The following is a description of a gene set: species: Homo sapiens The expansion, trafficking and functional effectiveness of adoptively transferred CD8+ T-cells play a critical role in mediating effective anti-tumor immunity. However, the mechanisms which program the highly proliferative and functional state of CD8+ T-cells are not completely understood. We hypothesized that IL-12, a cytokine commonly induced by TLR activation, could enhance T-cell priming by altering responsiveness to antigen and cytokines. Priming of tumor specific CD8+ T-cells in the presence of IL-12 induced the acquisition of a 'polyfunctional' effector response and increased the generation of memory cells. Moreover, IL-12 priming also promoted high levels of the IL-2 receptor alpha-chain (CD25) and robust IL-2 mediated activation of STAT5. This sensitivity to IL-2 translated into enhanced in vivo proliferation of adoptively transferred CD8+ T-cells. Furthermore, real-time, in vivo imaging of T-cell trafficking confirmed the ability of IL-12 priming to drive in vivo proliferation. IL-12 priming enhanced the anti-tumor function of adoptively transferred cells by reducing established subcutaneous tumor burden, and significantly increasing survival in an established intracranial tumor model. Finally, IL-12 priming of human PBMCs generates tumor specific T-cells phenotypically and functionally similar to IL-12 primed Pmel-1 T-cells. These results highlight IL-12 as an important mediator of CD8+ T-cell effector function and anti-tumor immunity. Human Gene Set: GSE22443_IL2_VS_IL12_TREATED_ACT_CD8_TCELL_UP Genes up-regulated in Pmel-1 CD8 T cells primed with cognate antigen: IL2 versus IL-12. from publication Lisiero DN, Soto H, Liau LM, Prins RM (PMID 21430221), and this is the list of marker genes: KRTAP4-3, RGL1, ACY3, GALNT10, PEX5, IFNB1, BBS7, TMEM52, CYP11B2, DMAC2, USP9Y, NUP188, SKA1, ABHD16A, NR2E3, LRRN3, VPS8, PTPN5, CLCNKB, MTMR2, RHOBTB3, PMP2, TEX261, PIGP, CAPN3, NRGN, TMEM91, KIF6, EFNA4, TMEM252, LIFR, DAB1, EGFR, CHRDL2, SSBP4, DMC1, NFKBIL1, RNF208, AKAP5, PIP5KL1, HRG (NCBI Gene Id 3273), SFRP4, CFAP36, TMEM102, MFN2, TMEM44, HOOK2, FAM83F, MATN3 (matrilin 3), FSTL5, VAMP1, RAB11FIP3 (NCBI Gene Id 9727), RAG2, LYZL4, NETO1, SMAD9, KHDC3L, ADGRF5, AIFM3, SLC38A7, ASCL2 (NCBI Gene Id 430), LOXL1, LIAT1, AUTS2, TBX5, ZNF565, CXCL13 (C-X-C motif chemokine ligand 13), CHGB, SLFN13, DNAAF4, FUT1, NOL3, STRBP, HPDL, FOXJ1, RNASEH2C, ALDH7A1, RNF126, RFC1, FOXD2 (forkhead box D2), TRIM71, GCM1, OTUD7A, MTNAP1, SLC4A11, NTRK1, PIGR, LAMA1, FOLR1, PTGES2, WFDC5, KERA, BNIP5, GJB5, REXO4, TRMT1, B3GALT1, TMEM131L, C14orf28, SLC26A5, TEX101, CASR, ENSG00000286190, LAP3, PSMF1, XRCC5, GSTZ1, CRYGS, FHIP1A, PAQR6, SEPHS1, HCFC2, PRTN3, TCEA2, PPP4R4, CAPN11, MRPL46, KRT27, TCL1A, MAP2, SLC7A14, STAC, PRELP, DYRK3, TRH, NKD1, TRIM42, PI4KB, NKPD1, DBNDD2, CBX6, TNFAIP8L1, SDCCAG8, RRP12, LIPF, HSF2BP, BCL2L14, RWDD2A, TAF3, FAM234B, CLDN16, TTI2, UPB1, NCAPH2, PIGK, CCR4, CALY, DCLRE1A, ZP1, HOXD11, TACR1, HACL1, MND1, SUDS3, C1orf54, AATK, P2RX3 (purinergic receptor P2X 3), TNNI3K (NCBI Gene Id 51086), MPV17L2, ST6GALNAC6, MRPS22, TRMT9B, NR1H3, CLDN14, CENPB, ATCAY, FKBP6, TMEM130, SHFL, GJC2, EXOSC2, EXOSC5, CD46, EML1, SYCE1L, MAN1C1 (mannosidase alpha class 1C member 1), ZNF48, RTKN2, MOGAT1, UGT2B10, BRD8, IL4R, SHC2, AQP6, DAGLA, GFPT2, LYZL6, TMPRSS4, LMF2, MAD1L1, C4orf36, ZNF750, SLC35F2, KSR1, KCNF1, PTCH1, TEX29, KRT20, KRT36